The following is a description of a gene set: Human Gene Set: GSE15659_RESTING_VS_ACTIVATED_TREG_DN studied in species Homo sapiens Genes down-regulated in comparison of resting regulatory T cell (Treg) versus activated regulatory T cell (Treg). from publication Miyara M, Yoshioka Y, Kitoh A, Shima T, Wing K, Niwa A, Parizot C, Taflin C, Heike T, Valeyre D, Mathian A, Nakahata T, Yamaguchi T, Nomura T, Ono M, Amoura Z, Gorochov G, Sakaguchi S (PMID 19464196) Gene expression profiles of subsets of CD4+ T cells according to their expression of FoxP3 and CD45RA were compared. FoxP3 is a key transcription factor for the development and function of natural CD4+ regulatory T cells (Tregs). Here we show that human FoxP3+CD4+ T cells are composed of three phenotypically and functionally distinct subpopulations: CD45RA+FoxP3low resting Tregs (rTregs) and CD45RA-FoxP3high activated Tregs (aTregs), both of which are suppressive in vitro, and cytokine-secreting CD45RA-FoxP3low non-suppressive T cells. The proportion of the three subpopulations characteristically altered in cord blood, aged individuals, and patients with immunological diseases. Terminally differentiated aTregs rapidly die while rTregs proliferate and convert into aTregs in vitro and in vivo as shown by the transfer of rTregs into NOD-scid-common gamma-chain-knockout mice and by TCR sequence-based T cell clonotype tracing in peripheral blood of normal individuals. Taken together, the dissection of FoxP3+ cells into subsets enables one to analyze Treg differentiation dynamics and interactions in normal and disease states, and to control immune responses through manipulating particular FoxP3+ subpopulations., and this is the list of marker genes: UBE2U, TFF2, SLC25A46, RBCK1, SEC24D, PPP2R1A, STK25, SLC44A3, U2AF1, SEPHS2, PYGL, SCO2, TTTY13, RAN, ZNF596, PSPN (NCBI Gene Id 5623), SLC4A9 (NCBI Gene Id 83697), TTL, EMC4, TRIP12, POLR3F, RD3, ZAN, RBM41, RANBP9, SAP30BP, RHOC, VAMP3, TMBIM1, RHOU, THRB, PTK2B, SOX2-OT, SNORA65, RAMP1, TNF, ZPBP2, TK1, POLR2F, TUSC2, SLC25A3, SLC39A1, RAP2B, ZDHHC8BP, DENND2B, ST7-AS1, PPM1B, ZNF385D, SRL, TNFAIP3, SLC22A18, HACD4, TRABD, PSMA2, SHISA6, EMC2, ZNRF2, RSPH1, PTPN23, WDHD1, RAB2B, TDRD7, ZNF34, SOX11, RAB9A, SARS2, STARD4, RANGRF, ZFAND5, SNX3, POLR1H, POP7 (POP7 homolog, ribonuclease P/MRP subunit), SLC43A3, TP53INP2 (tumor protein p53 inducible nuclear protein 2), TIPRL, RTP1, PPY, ZNF414, TPMT, ROCK1, CCN6, SLC9A8, STK36, RSPH3, SPATS2L, SLC24A5, THAP1, DNAAF10, PRDX4, ROS1, TOR1AIP1, NECTIN4, SYN2, ZBED6, TRIML1, TTC7A, SCN8A, UBL7, TULP2, S100P, TMEM139, RSPH10B2, PROCR, PPM1K, TIFAB, TOP1, RNF10, SPATC1, SPATA22, PSMG2, TPI1, ZNF618, ZC3H13, TOMM22, PSEN1, UTS2B, TSNAX, ZNF324B, EIPR1, LMNTD2-AS1, SUMO4, TMEM208, SMAP2, SLC6A7, TRPM6, ZNF678, ZCCHC9 (NCBI Gene Id 84240), STK32A (serine/threonine kinase 32A), ZFC3H1, RPL26L1, UBA3, TEX12, RCOR1, SDC3, PRAM1, TBC1D1, SNAP91 (NCBI Gene Id 9892), ZMIZ2, RNF150, SEPTIN3, SLC35F3, PPHLN1, SLC9A6, UNC13D, TMEM126A, ZNF287, ZNF394, SUSD1, TRIM55, ZNF28, TMEM70, RUSC1, DESI2, PRDX3, TNFSF12, TBC1D4, S1PR2, SPATA2 (NCBI Gene Id 9825), RIT1, RRM1, SLC26A6, RGS17, XAF1, PSRC1, RNF214 (NCBI Gene Id 257160), ZNF663P, TTC33, RNF167, WARS1 (NCBI Gene Id 7453), PRKX, SAGE1, STX10, TYK2, UBR5, SF3B1, UBE2D1, AFG2B, UGT2B17, UGGT1, UBFD1, PRG3, VPS28, GET1, SLC16A4, TRIP6, VCPIP1, PYHIN1, GFUS, SEC61B, YY1, SGO2, SH2D1A, RGS4, TRIM16 (NCBI Gene Id 10626), PPP2R5A, PPP2CA, SLFNL1, PRKAG3